Given this list of marker genes PAX8, NRM, PLA2G6, VPS50, ICE2, ARHGAP12, CNTN6, KIF21A, IL12RB2, ANKRD46, CEP85, ANTXR2, ORC3, FLOT2, NAT1, RETREG3, FAM222B, NSUN2, QNG1, NEUROG2, BLOC1S6, HECTD1, DAPP1, MFN2, BNIP2 (NCBI Gene Id 663), NUCKS1, NKAIN1, PANK3, EIF2S2, FEZ2, PEX19, AGRP, BNIP1, GOLGA7, GSC, AGR3, IPP, CPEB2, DMXL1, GGPS1, CTLA4, BANF1, LUC7L3, L2HGDH, CNTN2, MAL, GALNT6, FAM20B, MRPL37, EYA2 (NCBI Gene Id 2139), ARHGAP18, ALDH1B1, ACAD10, APPL2, AFM, GABRA6, MCM5, EEIG1, IFNGR1, DENND4C, PEX12, CITED2, ATP6V1E1, NAB1, KIF13A, GRK6, PHTF1, CHRNB2, GABPA, ALS2, MIGA2, LAP3, PLAAT1, GRWD1, CYP1A1, NUB1, GNAQ, LRP1B, C5orf15, GLUL, LRRC42, SLC25A51, MAGOHB, GPR50, MGLL, ASAH2, GML, F13B, CAMK2G, FAM120B, MLXIP, LAIR1, FBXL20, KCNAB2, ATL2, PARG (poly(ADP-ribose) glycohydrolase), NUP58, MIDN, HDAC2, CSF2RB, CCR1, NEK6, GPATCH2, DIP2B, HSPB3, LETMD1, TPGS1, CORIN, FLT3, DYRK3, GOLGA5, C21orf91, CPQ, PAPSS1, MTF2, CLPTM1L, ACVR1, PGF, NDUFS6, EFHD2, MTHFS, KRT13, IDH1, LYRM2, FUCA2, SMIM11, CROT, LRRC59 (NCBI Gene Id 55379), GIMAP6, ASZ1 (NCBI Gene Id 65976), RETREG2, MFSD5, NSG1 (neuronal vesicle trafficking associated 1), ATN1, RMC1, ITGB3BP, ELOVL2, NUCB2, IFITM2, BEX1, DIS3, NRIP1, BCAP31, ACSL6, IFT88, C2orf76, SPIDR, CXorf38, CELF2, MOGS, BRMS1, ILRUN, ERC1, ARF4, ABHD10, IDO2, MPP1, HTR5A, NUDT7, HEXA, FASTKD5, HNRNPK, PACRGL, JAK1, NEUROG3, HTR2B, LRP4, FCGR1A, ANLN, F5, NEK2, EFEMP2 (NCBI Gene Id 30008), PHLDA1, CCKBR, CASC3, H1-8, TMEM242, NDST1, METRNL, AKAP1, MCM3, CENPB, LBR, BIRC5, CD84 (NCBI Gene Id 8832), GRIK5, CILK1, CD248, AP3B1, AQP9, MOB4, KIAA0513, CDK16, NSMF, LIMK2, PHF2, SMIM3, DPP3, KDELR1, ELAVL1, here is a description of the gene set: Genes up-regulated in comparison of control dendritic cells (DC) at 0 h versus those stimulated with poly(I:C) (TLR3 agonist) at 0.5 h. mouse primary BMDCs were stimulated with tlr ligands and gene expression changes were profiled on Affymetrix arrays Human Gene Set: GSE17721_CTRL_VS_POLYIC_0.5H_BMDC_UP from publication Amit I, Garber M, Chevrier N, Leite AP, Donner Y, Eisenhaure T, Guttman M, Grenier JK, Li W, Zuk O, Schubert LA, Birditt B, Shay T, Goren A, Zhang X, Smith Z, Deering R, McDonald RC, Cabili M, Bernstein BE, Rinn JL, Meissner A, Root DE, Hacohen N, Regev A (PMID 19729616) species: Homo sapiens